The following is a description of a gene set: A chromatin adaptor activity that brings together a protein and a specific form of histone, either modified by a post-translational modification, or the unmodified form. Histone readers have roles in many processes, including in centromere function or in modulating the accessibility of cis-regulatory regions to the transcription machinery. Mouse Gene Set: GOMF_HISTONE_READER_ACTIVITY studied in species Mus musculus, and this is the list of marker genes: Ing2, Yeats2 (YEATS domain containing 2), Phf14, Msl3, Zzz3, Mecp2, Usp15, Stk38, Zzef1, Fgf2, Kdm4a, Tonsl, Uimc1, Kdm4c, Chd1l, Dpf2, Taf7, Thap7, Brd1, Taf1 (TATA-box binding protein associated factor 1), Cbx7, Ccdc38, Mdc1, Chd5, Cbx2 (chromobox 2), Brd7, Hdgfl2, Trp53bp1, Ttll12, Dnajc2, Brdt, Spin1, Zcwpw1, Pwp1, Rnf169, Mphosph8, Pih1d1, Cbx5, Jarid2